The following is a description of a gene set: Broad phalanges of the hand Increased width of the phalanges of the hand. studied in species Homo sapiens Human Gene Set: HP_BROAD_PHALANGES_OF_THE_HAND, and this is the list of marker genes: USP9X, SUMF1, MAP3K7, BPTF, KCTD1, GDF5, OFD1, FLNB, KCNH1, MED12, PYCR2, FBN1, DVL3, SMOC1, SETD5, COL10A1, TBX5, IFIH1, INPPL1, GJA5, SUZ12, FGFR2, RTL1, NXN, LMBR1, HS2ST1, FGF9, RBM8A, WDR19, DLK1, TRPM3, DACT1, CDKL5, H3-3B, DNM1L, GPC3, MSX2, FGFR1, RERE, EP300, SNIP1, MEG3, IFT56, GATA4, BMPR1A, GATAD2B, B3GALT6, PIK3CD, PUF60, CHST3, WNT5A, BICRA, COL2A1, BGN, BMP2, LIG4, FLNA, B3GAT3, PTEN, ACAN, ZNF141, ADNP, GNAS, NOG, MAN2C1, KNSTRN, G6PC3, KIF22, SATB2, RNU4ATAC, TWIST1, FGFR3, MEIS2, WLS, OTUD6B, NEPRO, IFT122, HPGD, SIAH1, NSUN2, ZNF668, SMO, H3-3A, ROR2, XYLT1, MEGF8, EZH2, PCDHGC4, EED, SALL1, RLIM, HNRNPR, PRKD1, DHX30, EXOSC2 (exosome component 2), CBFB, CREBBP, FBXO11, PSMD12 (NCBI Gene Id 5718), GPC4, SMARCA2, ALX4, AMMECR1, PACS1, SRCAP, GJA8 (gap junction protein alpha 8), POGZ, DVL1, ADAMTS10, PRKG2, HOXD13, EXTL3, GLI3, NSD1, RAB23